The following is a description of a gene set: Burn wound healing species: Mus musculus Mouse Gene Set: WP_BURN_WOUND_HEALING, and this is the list of marker genes: Pecam1, Vegfa, Ccl2, Tgfbrap1, S100a8, Nos2, Il1b, Fgf2, Il18, Tnf, Il6, Gja1, Nos3, Nlrp3, Lama1, Col1a1 (NCBI Gene Id 217123), Hbegf, Tgfb1, Acta1, Flii, Prodh2